The following is a description of a gene set: Genes predicted to be targets of miRBase v22 microRNA hsa-miR-6814-5p in miRDB v6.0 with MirTarget v4 prediction scores > 80 (high confidence targets). from publication Chen Y, Wang X (PMID 31504780) studied in species Homo sapiens Human Gene Set: MIR6814_5P, and this is the list of marker genes: FBXW10B, ANKDD1A, ELK1, LPP, MBD6, RC3H1, SPEF1, STXBP6 (NCBI Gene Id 29091), DEPDC1, ACRBP, ZNF367, ATP8B1, TMCC1, ZBTB5, TMEM65, ATP1B1, ARHGAP5, CAPN2, RBMXL1, EPX, BEND4, ALG14, MICAL2, MRPL35, AHSA1, ADIPOR2, DDN, PDIA6, NAV1, HEYL, SPATA6, NEK9, SDF2, MAT2A, MFAP1, CMTM5, SLC39A8, NOS1, TTC24, SRF (NCBI Gene Id 6722), LGSN, PYGM, SLC25A35, ZFP91, SEC24D, SRSF3, DDX42, ZFYVE27, TIMM10B, RTN1 (NCBI Gene Id 8108, reticulon 1), BZW2, DNAJB2, SSR3, ETV1, TBL2, PAPPA, USP1, BCL2L2, GCNA, RBMX (NCBI Gene Id 8258), R3HCC1L, PCGF5, AFMID, MMAB, VAPB, FAM163A, SLC9A5, RIMKLA, MED9, MYO1D, CA12, LCE1F, ALK, ATAT1, RABIF, RBBP4, VPS26B, FBXW11, GRAP2, ADCY1, STN1, FAM161A, SH3TC2, NHERF2, GBP6, HELZ2, NR1H2, CERT1, BCL9, CCM2L, CRISPLD1, PKMYT1, INSYN1, SEPTIN2, USP39, PTPN14, COL25A1, CCNJ, MTCH2, MACO1, NCOR2, PEX5, CXXC4, AMPH, ALDH1A3, KIF5B, AIDA, ASPH, THAP3, ZNF41, SHISA9, PGM5